Given this list of marker genes Kdm5a (lysine demethylase 5A), Shisa7, Mecom, Atf7, Ptar1, Rap1gds1, Gin1, Nabp2, Ttc13, Zfp775, Trmt10a, St8sia1, Mmp17 (NCBI Gene Id 23948), Abhd12, Ppp1r14c, Mcc, Erv3, St3gal1, Kmt2c, Slc13a4, Itga3, Slc16a14, Atp8b2, Add1, Dip2c, Gpank1, Sfxn3, Myoz3, Snrpc, Spidr, Mylk4, Klhl20, Gbf1, Prkn, Mprip, Pdk4, Ncapd3, Spred1, Kynu, Ak4, Styxl1, Ptpre, Pgrmc2, Ankrd13c (NCBI Gene Id 99810), Srgap2, Ptdss1, Inka2, Cby2, Ctns, Krt34 (keratin 34), Morc4, Mrps2, Atg13, Zfp664, 6430548M08Rik, Sec16b, Tmem184b, Eny2, Prkacb, Arhgap10, Tlcd5, Sfxn4, Rnf207, Chad, Fry, Emc6, Ifnlr1, Btf3l4, 2210408I21Rik, Thsd4 (NCBI Gene Id 207596), Nipal2, Pax1 (NCBI Gene Id 269372), Parp8, Dok5, Col12a1, Nab1, Zbtb4, Nop9, Ergic1, Zdhhc5, Rusc1, Trp53inp2, Brap, Slc25a51, Gucy1a2, A2ml1, Ica1l, Gpatch8, Dnaja4, Stx17, Cdkl3, Fancg, Oxsm, Cflar, Spock1, Trim67, Satb2, Vldlr, Car8, Sh2d1b1, Hook3, Fam168a, Arl6ip1, Slc23a2, Plxna2, Trim32, Smim3, Slc3a2, Umps, Tsc22d2, Ripor2, Erich3, Pcdhb3, Matcap1, Fzd3, Nr4a3, Setbp1, Bnc1, C5ar1, Pfkfb3, Cep43 (centrosomal protein 43), Kalrn, Rnf150, Pip5k1a, Smarcc1, Ttll7, Shisa9, Pfas, Gjb1 (gap junction protein, beta 1), Zfp937, Pik3c2b, Epha8 (NCBI Gene Id 230847), Txnl4a, Tle1, Cct8, Htr2c, Syt14, Ebf2, Angel1, Lrrtm2, Smchd1, Trim40, Ap1s1, Chrdl1, Ednrb, Nxf3, Cd300lb (CD300 molecule like family member B), Zfp169, Ulk3, Msx3, Fgf16 (NCBI Gene Id 80903), Ncr1, Ppp1r18, AI593442, Slc25a13, Atg4c, Dnajc1, Mthfd2l, Slc2a2, Mtcl2, Zeb2, Pkd2, Asph, Ttpal, Hif3a, Ap1s3, Spata17, Siglecl2, Bcam, Ociad2, Picalm, Sez6l, Tbx5, Zbtb16, Esrrg, Nipsnap1, Dab2ip, St7l, Enpp4, Car10, Rab6b, Seh1l, Blnk, Usp46, Gpr132, Thra, Marchf5, Nf2, Sap30bp, Tal1, Tead1, Stx2, Syt12, Hpgd, Cdk6, Fam234b, Rbbp4, Fancc, Lrrc39, Creb5, Hnf4a, Dusp22, Dnase2b, Samd1, 7530416G11Rik, Pip4p1, Suox, Spock2, Tmx4, Eif5a2, Prl5a1, Nr5a1, Sav1, Mpv17l, Traf1, Lekr1, Hmg20a, E2f3, Zfp395, Snhg11 (small nucleolar RNA host gene 11, NCBI Gene Id 99358), Cdc14b, Scimp, Pacs1 (NCBI Gene Id 245856), Nalcn, Tmem252 (NCBI Gene Id 226040), Tmem25, Nelfcd (negative elongation factor complex member C/D, Th1l), Ttc41, Smg6, Esp36, Onecut2, Trrap, Atp6ap1, Btg3, Gid4, L2hgdh, Atp6v1d, Cysltr1, Sh3gl2, Sdc4, Dmtf1l, Fuca2, Trim56, Jph4, Strbp, Jchain (NCBI Gene Id 68287), Ptpn14, Jakmip1, Parpbp, Cxcl9, Cd300lg, Aqp7, Ado, Wipf2, Crisp2, Atp1a2, Zfp592, Ptafr, Patl2, Dcaf7 (DDB1 and CUL4 associated factor 7), Mcu, Ralgapa2 (Ral GTPase activating protein, alpha subunit 2 (catalytic)), Ccl6, Pde6a, Sec62, Yju2b, Arrdc3 (NCBI Gene Id 105171), Ssh2, Or5b95, Atp10b, Grik3, Elmo1, Cdh8, Stim1, Als2, Jam3, Spin1, Cd274, Map3k5, E2f1, Sec61g, Blmh, Psme3, Prrg3, Bard1, Prrx1, H2bc6, Rtbdn, Abcb7, Nav1, Tmem138, Enah, Tshz2, here is a description of the gene set: Genes predicted to be targets of miRBase v22 microRNA mmu_miR_7054_5p in miRDB v6.0 with MirTarget v4 prediction scores > 80 (high confidence targets). species: Mus musculus Mouse Gene Set: MIR_7054_5P from publication Chen Y, Wang X (PMID 31504780)